Given this list of marker genes CYP2U1 (NCBI Gene Id 113612), CYP4V2 (NCBI Gene Id 64587), CYP1A1 (cytochrome P450 family 1 subfamily A member 1), CYP4F2, CYP4A22, CYP4F3, CYP4A11, CYP4F11, here is a description of the gene set: studied in species Homo sapiens Catalysis of the reaction: an omega-methyl fatty acid + O2 + reduced = an omega-hydroxy fatty acid + H+ + H2O + oxidized. Human Gene Set: GOMF_FATTY_ACID_OMEGA_HYDROXYLASE_ACTIVITY